Given this list of marker genes CAMK1G, CAMK2D, CAMK2B, CAMK2A, CAMK2G, here is a description of the gene set: Human Gene Set: GOCC_CALCIUM_AND_CALMODULIN_DEPENDENT_PROTEIN_KINASE_COMPLEX species: Homo sapiens An enzyme complex which in eukaryotes is composed of four different chains: alpha, beta, gamma, and delta. The different isoforms assemble into homo- or heteromultimeric holoenzymes composed of 8 to 12 subunits. Catalyzes the phosphorylation of proteins to O-phosphoproteins.